The following is a description of a gene set: species: Homo sapiens Genes down-regulated in dendritic cells versus those sorted as ITGAX int and EMR1 int. from publication Rivollier A, He J, Kole A, Valatas V, Kelsall BL (PMID 22231304) Dendritic cells (DCs) and macrophages (MPs) are important for immunological homeostasis in the colon. We found that F4/80hi CX3CR1hi (CD11b+CD103-) cells account for 80% of mouse colonic lamina propria (cLP) MHC-IIhi cells. Both CD11c+ and CD11c- cells within this population were identified as MPs based on multiple criteria, including a MP transcriptome revealed by microarray analysis. These MPs constitutively released high levels of IL-10 at least partially in response to the microbiota via an MyD88-independent mechanism. In contrast, cells expressing low to intermediate levels of F4/80 and CX3CR1 were identified as DCs, based on phenotypic and functional analysis and comprise three separate CD11chi cell populations: CD103+CX3CR1-CD11b- DCs, CD103+CX3CR1-CD11b+ DCs and CD103-CX3CR1intCD11b+ DCs. In non-inflammatory conditions, Ly6Chi monocytes differentiated primarily into CD11c+, but not CD11c- MPs. In contrast, during colitis, Ly6Chi monocytes massively invaded the colon and differentiated into pro-inflammatory CD103-CX3CR1intCD11b+ DCs, which produced high levels of IL-12, IL-23, iNOS and TNF. These findings demonstrate the dual capacity of Ly6Chi blood monocytes to differentiate into either regulatory MPs or inflammatory DCs in the colon, and that the balance of these immunologically antagonistic cell types is dictated by microenvironmental conditions. Human Gene Set: GSE27859_DC_VS_CD11C_INT_F480_INT_DC_DN, and this is the list of marker genes: IFI27L2, ACO2, TAF6L, SMC2, NUP37, DGCR2, RECQL, GUSB, GPS1, CDK4, SLC7A6, TXK, CBX3, SSRP1, KCTD17, CTDP1, TNFSF9, ASB15, SLC44A1, NOL12, ALYREF, MIF, RPP40, ZCCHC3, PPIA, PLK1, FANCA, UBAP2, TMEM183A, ANKRD28, PCGF6, MTREX, PCBD2, ATP13A1, NFKBIZ, MRPL20, MMS22L (MMS22 like, DNA repair protein), EIF4A3, CBL, COPG2, COQ6 (coenzyme Q6, monooxygenase, NCBI Gene Id 51004), EIF4ENIF1, GYPC, NUP188, RBMXL1, ABHD10, RNF38, ABI3BP (NCBI Gene Id 79859), SH3BP2, NEFH, MECP2, NUP93, RAN, MTX1, POLE3, CDK1, UTP25, C1QBP, RBM8A, PSMD3, LRRC8C (NCBI Gene Id 84230), PTEN, PRMT7, GTF3C5, ERCC6L, PSMC1, NHP2, ORC2, TPCN1, KRAS (NCBI Gene Id 3845), TADA2A, DLST, STYX, GALNT11, PPP3CB, CNOT9, PPIH, SRSF9, DPH5, NINJ2, PRKRIP1, SLAMF6, PSMD14, POLR2B, STXBP6, TBRG4, YWHAQ, ATP10A, AHCTF1, PSMB3, EEF1AKMT1, TRIP13, ATP5MK, RCL1, GINS1, NAF1, NOLC1, CMTM6, DIS3, PM20D1 (peptidase M20 domain containing 1), SERF1A, WDR43, SMIM12, PTPRS, FOXP1, PCNA, MAFK, KAT2A, SPC25, DTYMK, MTRES1, SAP18, COX6C, LAMP1, SMO, ENPP3, MCM7, POT1, HBP1 (HMG-box transcription factor 1), ZNF326, MRPL16, MOGS, CAND1, SNRPC (NCBI Gene Id 6631), RNF126, CFD, CCT3 (NCBI Gene Id 7203), CLNS1A, CD200, TMEM109, POLR2K, HSF1, GSPT1, HNRNPU, FIG4, NSUN2 (NOP2/Sun RNA methyltransferase 2), MKLN1, SF3A2, TFDP1, MAGOH, MCM4, ASTE1, WEE1, GNL3, TNK2, MMD, MYH8, PSIP1, MYO5A, PRPS1, PSPC1, EXO1, GFER, WDHD1, PTPN9, AATF, FGF13, RDH13, DHX15, SYCE2, PRMT3, DIABLO, BAZ1B, HEXD, CAD (NCBI Gene Id 790), DYNLL2, PUF60, HEATR1, TYSND1, PHB1, HEATR5B, HNRNPC, FUT8, BYSL, PSMB6, MAPK6, CCN3, ZWILCH, UTP18, PARP2, TRAP1, SNRPA1, MIS18A, PABPC4, SNX10, MOV10, FABP5 (NCBI Gene Id 92424), NUP85 (nucleoporin 85), SEPTIN7, UBE2K, ABHD8, MTF2, CPSF1, BRCA2, SAMM50, NDUFS8, CENPB, POLR3G, NUTF2, TUBB